Given this list of marker genes Ttc21b, Nkx2-1, Wnt2b, Gli3, Adgrg1, Otx2, Bmp2, Dmrta2, Lhx1 (LIM homeobox protein 1), Gsx2, Six3, Emx1, Tra2b, Nr2f1, Pgap1, Fezf2, Wnt1, Eomes, Wnt7b, Fezf1, Bhlhe22, Lhx2, Pax6, Shh, Fgf8, Bmp4, Emx2, here is a description of the gene set: The regionalization process resulting in the creation of areas within the forebrain that will direct the behavior of cell migration in differentiation as the forebrain develops. studied in species Mus musculus Mouse Gene Set: GOBP_FOREBRAIN_REGIONALIZATION